Given this list of marker genes FCGR1A, FLT1, GPR156, NPAS4 (NCBI Gene Id 266743), UHRF1, CREBRF, C4orf46, ELAC1, KCNIP2 (potassium voltage-gated channel interacting protein 2), PTGES3, CCNI2, RPN2, WDR64, VPS53, NCAPG, PLCXD2, METTL4, NR2C2, TSPAN17, PHC3, GOLT1A, RNF168, KLK4, AGK (acylglycerol kinase), JADE3, PROK2, CPD, ZFPM2, CHAMP1, OTUB2, RAN, NKX3-1, RAB10, NUAK2, AK7, SULF1, NHSL3 (NCBI Gene Id 57648), ZNF124, PIM2, ATXN7L3B, here is a description of the gene set: Genes predicted to be targets of miRBase v22 microRNA hsa-miR-378b in miRDB v6.0 with MirTarget v4 prediction scores > 80 (high confidence targets). from publication Chen Y, Wang X (PMID 31504780) studied in species Homo sapiens Human Gene Set: MIR378B